The following is a description of a gene set: from publication Yevshin I, Sharipov R, Kolmykov S, Kondrakhin Y, Kolpakov F (PMID 30445619) Human Gene Set: PBXIP1_TARGET_GENES Genes containing one or more binding sites for (PBXIP1) in their promoter regions (TSS -1000,+100 bp) as identified by GTRD version 20.06 ChIP-seq harmonization. studied in species Homo sapiens, and this is the list of marker genes: ACTB, CRELD2, CLDN14, NDUFB10, PIANP, RPL18AP3, PRR18, CCDC107, ST13P5 (ST13, Hsp70 interacting protein pseudogene 5), RPL39P3 (NCBI Gene Id 285785), CYP2S1, THRSP, CCDC85C, SHROOM1, RNA5SP379, SLC51A, HSF1, MIR196A1, SNX33P1, RN7SL340P, RNA5SP84, DMKN (dermokine), RPL34P27, PSMC5, LBX1, RN7SK, LINC01270, PTH2, PTK2B, ENSG00000260660, SCGB2B3P, KRT42P, ENSG00000235779, ACY3, ENSG00000271776, JRK, CSTPP1, SNORD14C, QRFP, C3orf86P, CALR, WDR83OS, SAP25, MIR663B, LINC02746, VPS36, FGF21, HSP90AA2P, SLC25A3, ACOXL, SH3BP2, KRT87P, RPL12P33, CDH5, ARHGEF11, TRAPPC12, GMIP, TBL2, CCDC97, TMEM219, TPRG1, CFAP119, PCGF3-AS1, ILF3, DLGAP4, PTPRG-AS1, TUBA1B-AS1 (TUBA1B antisense RNA 1), CRYBG2, NDUFA4P1, RPS29, LINC01093, KCTD1, SLC39A12, CYFIP1, NDRG4, WDR83, EDC4, ARL2BPP4, CSGALNACT2-DT, ACSL6, SUGT1P4-STRA6LP-CCDC180, TNFRSF13C, KRT5, MIR770, FTH1, SMUG1, EMSLR, ZP3, SMAD3, PODXL, RELN, MIR4507, MED12L, PREX1, VPS51P6, ARHGEF2, BCKDK, SNHG14, KCNA1, GFY, HOXB7, VIPR2, DIPK1B, DPYSL5, CSGALNACT2, KSR1P1, ENTPD8, SLC26A5, LIPG, HNRNPA2B1, HSPA8 (NCBI Gene Id 3312), TSHZ2, ASS1, GSTA4, ZFPL1, PDE6G, PRAMEF18, GAL3ST2 (galactose-3-O-sulfotransferase 2), SLC44A4, KCNIP3 (NCBI Gene Id 30818), TRBV3-1, ANO1, GPR78, SUGT1P4, TNS3, HMGA2, LINC01310, DNMT1, SLK, GSG1L, XRCC1, TMEM265, PABPC1, GPIHBP1, GREB1L, THBS1, SPAG7, FN1-DT, GLB1L3 (galactosidase beta 1 like 3), CD68, FBRSL1 (NCBI Gene Id 642031), PRSS51, FCGBP, NCR2, CHAD, KIF21B, MMP17, RPL24P4, LILRP2, ZMIZ2, CEP104, GRB14, HAUS6P3, WEE1P1 (NCBI Gene Id 100129037), PMEL, AAAS, GREB1L-DT, IGHD1-26, IGHA2, SH3YL1 (NCBI Gene Id 26751), NRXN1, MIR4538, SLMAP, TCF3, IGF2R, HOTTIP, UHRF2, SNORD14D, CABP1-DT, AGAP3, CSMD3 (NCBI Gene Id 317683), RAB37, DKKL1P1, VGLL2, DPP9, WIZ, CMTM5, FUT1, CTBP1 (NCBI Gene Id 1487), UBR5, SLC25A23, SIDT2, WDHD1, RPS16P9, GOLGA6L7, FEZF1, FBF1, SPATA3, EVC2, PDE4C, ZNF593OS, B4GALNT1, PAH, CNTNAP5-DT, DTX1, MAU2, NCAPG2, PAMR1, RDH13 (NCBI Gene Id 112724), LINC02074, CDCA7L, UNC5D, MX2, ACSF2, CD19 (NCBI Gene Id 930), NOTCH4, RNU6-994P, TTC3, KRT18 (keratin 18), GRAMD1B, SNORD115-13, FAM114A1 (NCBI Gene Id 92689), RCAN3, AHRR, PLEKHA6, ATP8B1-AS1, TNS2, B2M, PARP2, ACP1, SGSM3, ZMIZ1, VWA2, SMIM17, DTX3, SAPCD2P4, TTC34, ZDHHC11, SERPINA13P, INHA, EPHB6, ECHDC3, SUGT1P4-STRA6LP, NDST2, TMSB4XP8, NRXN3, PPIAP22, LGR6, LINC00895, FADS2, TMEM178B, CDCA5, DEGS2, ATG4B, GDF6, FBLN2, PDCD5, CYP26C1-DT, NUDT10, RPS15AP1 (NCBI Gene Id 92682), PRKAR1B, ZNF496, SLC13A5 (solute carrier family 13 member 5), NFATC1, IGLV1-40, KNSTRN, ACE, C2orf72, RPL15P3, FDFT1, ABR, KLC3, H3C4, ZFP41 (ZFP41 zinc finger protein), GAREM2, MT2P1, FEZF1-AS1, CYP26C1, AP3D1, FUNDC2P2, DAB1, ZFP64, NDUFB3, ERICH6B, SLC17A7, MALAT1, RANBP3, TUBB8, KPNA6, SAMD11, NPIPB2, GAS6, IL18BP, BLTP2